Given this list of marker genes BBS9 (Bardet-Biedl syndrome 9), STEAP2, GRM6, OTUD4, FMO3, PEAK1 (pseudopodium enriched atypical kinase 1), ARL17A, PNN, PPM1A, MTTP, NAT8L, RNF220, TRIB2 (NCBI Gene Id 28951), SAXO1, MCU, TPH2, HS3ST3B1, P4HA3, TPGS2, PROX1, RALGAPB, MTM1, ZNF749, GRID1, GLRX3, KMT2C, PEX5, RCN2, PDZD2, RLN1, KBTBD8, MEI4, PCDHA12, GOLGA8A, SPRED2, PRRC2C, CTBP1, NXPH1, PCDHA5, FCHO2, GPAM, ADAMTS5, NRXN1, MAGEE1, HACE1, RAI2, PCGF3 (NCBI Gene Id 253443), ASXL1, ARID1A, RC3H1, PCDHA4, MITD1, FAM133B, CDC14A, CDYL, CPED1, ZBTB21, CEP41, MYO1E, SNAI2, PMP2, CKAP5, WFDC6, NWD2, PCNP, C10orf88, HNRNPA3, APRG1, PCDH7, TBX15, PISD, CACNA1B, DCAF10, UBE2Q1, CDH13, STK35, PCDHA11, FOXN3, PPARGC1A (NCBI Gene Id 10891), PI4K2A, KATNBL1, CTPS2, MGARP, ATP1B1, HOOK3, AKAP1, WDR35, NFIX, ADCYAP1, SLC26A3, DAGLA, PDIA6, AUTS2, ULBP1, TMEM67, FGF1, PPP3R1, MZT1, RNF146, ZFAND5, CDK14 (cyclin dependent kinase 14), SMPX, TANC1, GNB1, CDH19, WDR7, ILRUN, GALNT1 (NCBI Gene Id 2589), HDAC4, TNPO1, NLK, ALDH18A1, DNAAF10, ANK3, PCDHA3, SEMA3C, CCDC68, RNF145, PLCL2, EFCAB5, TANC2, LCORL (NCBI Gene Id 254251), DNM1L, NSMCE4A, ZNF454, CD36, MPHOSPH8, RIOX1, CD46, DLC1, GRIA4, RUNX2, GABRA4, ZNF302, KLF6, SIRT1, CDH15, KMT5A, DYNLT5, AZIN1, CAMSAP1, SLC40A1, GDA, KIF21A, CDK16, PCDHA7, PCDHA13, GALC, NR1D2, PCDHAC1, PUM2, RAB38, PCDH18, TSHZ3, GOLGA6C, PDCD6IP, TENM1, LGALS8, RYR2, ST6GAL2, PDE10A, TENT2, ARID4B, PLA2G4A, RAB21, NRF1, PCDHAC2, SLC49A4, UBR3, ARHGAP20 (Rho GTPase activating protein 20), ZNF233, PIGK, C22orf39, PCDHA2, GOLIM4, UNC80, SLC7A14, PCDHA6, ZC3H13, GDAP2, EDNRA, NECTIN3, ZNF124, JAG1, DENND1B, ZNHIT6, KCNQ5, POLR3GL, UGT8, CREBRF, DMXL2, NAALAD2, PCDHA1, TTI2, MAP2K1, RUFY2, NRG1, BCOR, PPP4R4, MUC15 (NCBI Gene Id 143662), ITM2A (NCBI Gene Id 9452), CCDC85A, TMEM184B, SYPL1 (synaptophysin like 1), HCN1, ZNF397, PCDHA10, FBN2, ENY2, GTF3C3, PTPN2, RORA, SMG1, TMSB10, CEP170, LEPR, FAM168A, SP3, LIPT2-AS1, ASAP2, CNR1, ABHD17B, XG, DIAPH1, GIGYF2, CEP192, CUL3, FAM222B, YPEL4, TPP2, ELAVL2, here is a description of the gene set: Genes predicted to be targets of miRBase v22 microRNA hsa-miR-485-3p in miRDB v6.0 with MirTarget v4 prediction scores > 80 (high confidence targets). Human Gene Set: MIR485_3P species: Homo sapiens from publication Chen Y, Wang X (PMID 31504780)